Given this list of marker genes NR1D2, SEC22B, AMD1, DNMT1, STRN, ANKRD2, LRBA, KLRG1, ELMOD2, C1QTNF7, PARP1, ZWILCH, TUT7 (terminal uridylyl transferase 7), CLDN1, CXCL11, PRC1, NFAT5, LYPD6, CRYBG3, TTC33, CYP26A1, ERCC4, STRN3, PPP1R15B, TRIM59, CCDC126, H3-3B, USP25, ALS2, ADD3, GSG1, TRIM45, TAS2R14, TTC3, AREL1, MTMR2, OLFM4, DCSTAMP, ABCB5, RBMS3, ARHGAP11A, LINGO2, TXNDC8, FOXF2, MRPL53, here is a description of the gene set: from publication Chen Y, Wang X (PMID 31504780) Human Gene Set: MIR4536_5P Genes predicted to be targets of miRBase v22 microRNA hsa-miR-4536-5p in miRDB v6.0 with MirTarget v4 prediction scores > 80 (high confidence targets). species: Homo sapiens